The following is a description of a gene set: Genes up-regulated in 9.5 days post coitus (dpc) embryos with COMMD1 knockout and in normal 8.5 dpc embryos compared to normal 9.5 dpc embryos. species: Mus musculus COMMD1 (previously known as MURR1) belongs to a novel family of proteins termed the copper metabolism gene MURR1 domain (COMMD) family. The 10 COMMD family members are well conserved between vertebrates, but the functions of most of the COMMD proteins are unknown. We recently established that COMMD1 is associated with the hepatic copper overload disorder copper toxicosis in Bedlington terriers. Recent in vitro studies indicate that COMMD1 has multiple functions, including sodium transport and NF-kappaB signaling. To elucidate the function of Commd1 in vivo, we generated homozygous Commd1 null (Commd1(-/-)) mice. Commd1(-/-) embryos died in utero between 9.5 and 10.5 days postcoitum (dpc), their development was generally retarded, and placenta vascularization was absent. Microarray analysis identified transcriptional upregulation of hypoxia-inducible factor 1 (HIF-1) target genes in 9.5-dpc Commd1(-/-) embryos compared to normal embryos, a feature that was associated with increased Hif-1alpha stability. Consistent with these observations, COMMD1 physically associates with HIF-1alpha and inhibits HIF-1alpha stability and HIF-1 transactivation in vitro. Thus, this study identifies COMMD1 as a novel regulator of HIF-1 activity and shows that Commd1 deficiency in mice leads to embryonic lethality associated with dysregulated placenta vascularization. Mouse Gene Set: VANDESLUIS_COMMD1_TARGETS_GROUP_4_UP from publication van de Sluis B, Muller P, Duran K, Chen A, Groot AJ, Klomp LW, Liu PP, Wijmenga C (PMID 17371845), and this is the list of marker genes: Clic6, Slc2a1, Ttr, Spink1, Apoe, Ctla2a, Afp, Apom, Nr6a1, Lgmn, S100g, Apoa1, Apool, Tcfl5, Car4, Slc2a3, Emb, Trap1a, Krt18